The following is a description of a gene set: Human Gene Set: HP_LIMITATION_OF_MOVEMENT_AT_ANKLES An abnormal limitation of the mobility of the ankle joint. Limitation of movement at ankles studied in species Homo sapiens, and this is the list of marker genes: MAP3K7, LMNA, NIPA1 (NCBI Gene Id 6686), OCA2, UBE3A, FLNA, SCO2, ZMPSTE24